The following is a description of a gene set: Human Gene Set: HOFFMAN_CLOCK_TARGETS_UP The transcription factors responsible for maintaining circadian rhythm influence a variety of biological processes. Recently, it has been suggested that the core circadian genes may play a role in breast tumorigenesis, possibly by influencing hormone regulation or other pathways relevant to cancer. To evaluate this hypothesis, we conducted a genetic and epigenetic association study, as well as a transcriptional profiling array and a pathway-based network analysis. We report significant correlations between single nucleotide polymorphisms associated with the central circadian regulator CLOCK and breast cancer risk, with apparent effect modification by estrogen receptor/progesterone receptor status. We also found that hypermethylation in the CLOCK promoter reduced the risk of breast cancer, and lower levels of CLOCK expression were documented in healthy controls relative to normal or tumor tissue from patients with breast cancer. Finally, we silenced CLOCK in vitro and performed a whole-genome expression microarray and pathway analysis, which identified a cancer-relevant network of transcripts with altered expression following CLOCK gene knockdown. Our findings support the hypothesis that circadian genes influence tumorigenesis, and identify a set of circadian gene variants as candidate breast cancer susceptibility biomarkers. from publication Hoffman AE, Yi CH, Zheng T, Stevens RG, Leaderer D, Zhang Y, Holford TR, Hansen J, Paulson J, Zhu Y (PMID 20124474) Genes up-regulated in MCF7 cells (breast cancer) upon knockdown of CLOCK by RNAi that also belong to the highest confidence network (according to Ingenuity Pathway Analysis). species: Homo sapiens, and this is the list of marker genes: CD36, ANTXR1, MIF, JUN, TNFRSF11B, UGT2B17, HOXA7, UGT2B15 (NCBI Gene Id 94476), ANXA1, UGT2B10